Given this list of marker genes ITM2B, ELF4, ADD3, PTK2B, PGD, AGO1, PSMB9, CDKN2C, COL9A2 (collagen type IX alpha 2 chain), DEFA1, PIM1, RCBTB2, WAS, ALAS1, REL, WIPF1, here is a description of the gene set: from publication Xu K, Guidez F, Glasow A, Chung D, Petrie K, Stegmaier K, Wang KK, Zhang J, Jing Y, Zelent A, Waxman S (PMID 16140955) Differentiation induction is an effective therapy for acute promyelocytic leukemia (APL), which dramatically responds to all-trans-retinoic acid (ATRA). Recent studies have indicated that combinatorial use of retinoid and nonretinoid compounds, such as histone deacetylase inhibitors, arsenics, and PKA agonists, has higher therapeutic value in this disease and potentially in other malignancies. In a screen of 370 compounds, we identified benzodithiophene analogues as potent enhancers of ATRA-induced APL cell differentiation. These effects were not associated with changes in global histone acetylation and, for the most potent compounds, were exerted at very low nanomolar concentrations, and were paralleled by enhancement of some, but not all, ATRA-modulated gene expressions. Investigating the mechanism underlying the effects of these drugs on ATRA-induced APL cell differentiation, we have shown that benzodithiophenes enhance ATRA-mediated dissociation and association of corepressor N-CoR and coactivator p300 acetyltransferase, respectively, with retinoic acid receptor (RAR) alpha proteins. These data suggest that benzodithiophenes act at the level of receptor activation, possibly by affecting posttranslational modification of the receptor (and/or coregulators), thus leading to an enhancement in ATRA-mediated effects on gene expression and APL cell differentiation. Given the specificities of these low benzodithiophene concentrations for PML-RARalpha and RARalpha, these drugs may be useful for combinatorial differentiation therapy of APL and possibly other acute myelogenous leukemia subtypes in which the overall ATRA signaling is suppressed. species: Homo sapiens Human Gene Set: XU_RESPONSE_TO_TRETINOIN_UP Genes up-regulated in NB4 cells (acute promyelocytic leukemia, APL) by tretinoin alone.